Given this list of marker genes ZNF426-DT, ZNF446, IK, ARL6IP1, ZNF335, SH3PXD2A-AS1 (SH3PXD2A antisense RNA 1), BLCAP, AAGAB, PNISR, ZNF426, CCDC121, NDUFA2, PPP2CA-DT, BLOC1S2, IQCH (NCBI Gene Id 64799), MYG1, TMEM19, PPP2CA, GPN1 (NCBI Gene Id 11321), SUGT1-DT, here is a description of the gene set: Genes containing one or more binding sites for (MSX2) in their promoter regions (TSS -1000,+100 bp) as identified by GTRD version 20.06 ChIP-seq harmonization. studied in species Homo sapiens from publication Yevshin I, Sharipov R, Kolmykov S, Kondrakhin Y, Kolpakov F (PMID 30445619) Human Gene Set: MSX2_TARGET_GENES